The following is a description of a gene set: The ring-like, filamentous structure located at the distal end of the midpiece of the sperm flagellum; the annulus is thought to form a diffusion barrier between the midpiece and the principal piece and serve as a stabilizing structure for tail rigidity. species: Homo sapiens Human Gene Set: GOCC_SPERM_ANNULUS, and this is the list of marker genes: SEPTIN2, SEPTIN12, SEPTIN6, ADGB, DDX6, CBY3, SEPTIN7, SEPTIN4, CIBAR1 (NCBI Gene Id 730572), SLC26A8